Given this list of marker genes DYNLT2B, FAM162A, KLHL18, SYTL1, TMEM81, ZNF786, LFNG, TMEM71, CACNA1A, SLC30A7, TMEM237, ZCRB1, RCN1, CYP26A1, PRMT3, TMTC4, ARK2C, OXNAD1, MRPS24, IFNG, SLC35G1, PRDX3, FKBP9, KCTD10, GABRA3, GUK1 (NCBI Gene Id 2987), OSGIN2, DANCR, GRWD1, SERPINA7, YBX1, NIN, ACSL5, HDDC2, HLF, MRPL28, TSEN2, RPS18, ERAP1, LANCL3, CD74, AZIN2, PRXL2A, CABP7, GDF11, KCNV2, DPM1, CCDC187, PRODH2, HECW2, PPIB, ARHGAP18, GJB2, POLE2, PAOX, ISYNA1, TPST2, SLC12A2, ABCD2, CPVL, FSTL3, ADAR, ISL1, ORAI3, HSPE1, SKIC3, SLC47A1, KAT2A, EID2, RFC5, JAK3 (NCBI Gene Id 3718), DYNLRB2, GRAMD2B, NFATC2, PLPPR2, POLE, SMCO4, ITPK1, SOX10, PGF, PRPF31, BTF3, TOMM40, NHLRC1, CEP15, OXCT1, TMEM33, PPIC, CLN3, SCFD2, PMEPA1, PFKP, VPS25 (NCBI Gene Id 84313), LRRC8C, WDFY1, IDH3A, DHRS7, MAPK12, THTPA, PPRC1, SPATA33, UAP1, ARL1, PAK2, PPIL3, DNAJC19, GP1BA, PARP2, RARS1, KCNMA1, DPF3, ST6GALNAC4, RPL38, PIGS, AFP, POU2AF1, DRC1, TM9SF2, DSCC1, RFC4, MIOX, ADGRG3, ABCA2, MYO6 (NCBI Gene Id 4646), EMP3, TRAIP, NOL11, MAP3K4, LIPC, TSACC, PROKR1, TOMM40L, PEPD, SGSH, CCDC88C, AQR, NQO1 (NAD(P)H quinone dehydrogenase 1), TOPBP1, ARRDC5 (NCBI Gene Id 651041), HLA-DMA, ALPG, DOCK5, MTCH2, KRT15, ARHGEF3, POLR1B (RNA polymerase I subunit B), PHLPP2, PRKAR2A, SLFN13, TTC27, ERI3, NSDHL, MBOAT1, BTBD6, MROH2A, ACTN2, VIL1, ROCK2, INPP1, SMYD4, RABEPK, SPTB, DHX35, BRI3BP, HSPA9, BCKDK, NUFIP1, CEP250, ENO3, PML, TSFM, HORMAD2, SARS1, PHF7, TIMM8A, DSE, CIB3, ATP5MG, ELOVL5, ENC1, CYP20A1, CACNB2, RXRA, FGFBP3, PSMA5, GJA1, GRAMD4, DEPDC5, ITGB7, SCLT1, NSUN2, PRKDC, NME4, IRAK1, NUP155, TONSL, TMEM126A, ADSL, POLR1C, MTUS2, here is a description of the gene set: species: Homo sapiens Human Gene Set: GSE13493_DP_VS_CD8POS_THYMOCYTE_DN Genes down-regulated in comparison of CD4 CD8 thymocytes versus CD8 thymocytes. T cell development relies on the precise developmental control of various cellular functions for appropriate positive and negative selection. Previously, gene expression profiling of peptide-driven negative selection events in the N15 TCR class I MHC-restricted mouse and D011.10 TCR class II MHC-restricted mouse has offered insights into the coordinate engagement of biological processes affecting thymocyte development. However, there has been little comparable detailed in vivo global genome expression analysis reported for positive selection. We used microarrays to identify the genes differentially expressed during CD8 single positive T cell development in N15 TCR transgenic Rag2 deficient mice. from publication Choi YI, Duke-Cohan JS, Ahmed WB, Handley MA, Mann F, Epstein JA, Clayton LK, Reinherz EL (PMID 19027330)